Given this list of marker genes Slirp, Lrpprc, Pnpt1, Supv3l1, Grsf1, here is a description of the gene set: Mouse Gene Set: GOBP_REGULATION_OF_MITOCHONDRIAL_RNA_CATABOLIC_PROCESS Any process that modulates the frequency, rate or extent of the chemical reactions and pathways involving catabolism in the mitochondrion of RNA transcribed from the mitochondrial genome. studied in species Mus musculus